The following is a description of a gene set: Human Gene Set: KEGG_MEDICUS_REFERENCE_N_GLYCAN_PRECURSOR_BIOSYNTHESIS_GLC_6P_TO_MAN_P_DOL N-Glycan precursor biosynthesis, Glc-6P to Man-P-Dol. Pathway ID: N00667. Pathway type: Reference. Pathway class: nt06015 N-Glycan biosynthesis. species: Homo sapiens Pathway Definition from KEGG: Glc-6P -- GPI >> MPI >> PMM1/2 >> GMPP >> DPM1/2/3 -> Man-P-Dol, and this is the list of marker genes: MPI, DPM1, GPI, PMM1, GMPPA, GMPPB, DPM3, DPM2, PMM2